The following is a description of a gene set: species: Homo sapiens Human Gene Set: REACTOME_TP53_REGULATES_TRANSCRIPTION_OF_DNA_REPAIR_GENES TP53 Regulates Transcription of DNA Repair Genes, and this is the list of marker genes: CHEK1, POLR2B, CDK12, NELFE, GTF2F1, FANCC, CCNT2, FANCD2, CDK13, POLR2H, ELOA2, ELOB, GTF2F2, NELFCD, MSH2, POLR2G, CCNK, SSRP1, POLR2J, MLH1 (NCBI Gene Id 4292), POLR2A, RAD51D, TP53, ATM, DDB2, MDC1, JUN, SUPT5H, POLR2K, GTF2H2, GTF2H1, GTF2H3, ATF2, GTF2H4, NELFA, CCNT1, ELOC, ATR, FANCI, POLR2L, POLR2F, ELOA, CCNH, SUPT16H, ERCC2, ERCC3, FOS, POLR2I, GTF2H5, BRCA1, POLR2C, NELFB, ELL, SUPT4H1, MNAT1, CDK7 (cyclin dependent kinase 7), CTDP1, POLR2E, PMS2, CDK9, POLR2D, TCEA1